The following is a description of a gene set: species: Homo sapiens Any process that activates or increases the frequency, rate or extent of telomere capping. Human Gene Set: GOBP_POSITIVE_REGULATION_OF_TELOMERE_CAPPING, and this is the list of marker genes: TNKS, NABP2, HNRNPD, TNKS2, RTEL1